Given this list of marker genes HNRNPAB, NDUFV2, BUB3, TUFM, H2AZ1, SDHB, POM121, DDX21, HNRNPA3P1, MAPRE1, SET, ATP5PO, DDX49, PARK7, CALM3, SKP1, TATDN2, SNRPE, STARD7, CHD4, SRSF9, ANAPC5, HNRNPM, EDC4, MTDH, CYCS, PRPS2, HNRNPD, UQCRFS1, VBP1, WDR43, TAF11, TRA2B, SUMO1, SRRM1, NDUFS3, NDUFV1, U2AF1, DHX15, TLK1, CTCF, RAD23A (NCBI Gene Id 5886), NONO, MRPL9, IFRD1, POLE3, SMC3 (structural maintenance of chromosomes 3), RO60, CBX3, SLBP, EIF1AX, UBE2N, KIF2A, MAGOH, HNRNPR, DKC1, PDIA6, SF3A1, SLC25A3, KHDRBS1, HDAC1, HAT1, ATXN10, DDX19A, DDX39B, SRSF1, UBE2L3, KXD1, HSPA9, FUS, TARDBP, PTPN11, EIF4H, CDC123, SF3B2, PPM1G, DNAJC9, PTGES3, CCT2, PRRC2C, ACP1, SNRNP200, SRSF3, ILF3, VDAC2, CHERP, UBA2, DR1, ATP5PF, DDX19B, SNRPA1, UBAP2L (NCBI Gene Id 9898), ATP5MC3, TRIM28, HCCS, here is a description of the gene set: Neighborhood of UBE2N Neighborhood of UBE2N ubiquitin-conjugating enzyme E2N (UBC13 homolog, yeast) in the MORF expression compendium species: Homo sapiens Human Gene Set: MORF_UBE2N